The following is a description of a gene set: Human Gene Set: WP_IL5_SIGNALING studied in species Homo sapiens IL5 signaling, and this is the list of marker genes: JUN, SYK, MYC, PTPN11, SOS1, RAF1, IL5RA, GRB2, RPS6, RPS6KA1, STAT5A, STAT1, LYN, RPS6KB1, BTK, GSK3A, MAPK3, IL2, GSK3B, SPRED1, ELK1, SHC1, JAK2, PIK3CG, CSF2RB, FOXO3, FOS, STAT5B, MAP2K1, MAPT, KRAS, JAK1 (Janus kinase 1), AKT1, STAT3, MAPK1, PIK3R2, BCL2, MAP2K2, PIK3R1, RPS6KB2